Given this list of marker genes Tcf7, Tcf7l2, Tcf7l1, Ctnnb1 (NCBI Gene Id 12387), here is a description of the gene set: electronically inferred by orthology from the curated human pathway Reactome Pathway: RUNX3 regulates WNT signaling This event has been computationally inferred from an event that has been demonstrated in another species.<p>The inference is based on the homology mapping from PANTHER. Briefly, reactions for which all involved PhysicalEntities (in input, output and catalyst) have a mapped orthologue/paralogue (for complexes at least 75% of components must have a mapping) are inferred to the other species. part of: Transcriptional regulation by RUNX3 studied in species Mus musculus